Given this list of marker genes MYLK2, ANKRD10, ABL1, ATP1B3, AIPL1, SS18L1, WFDC12, STK4, ANO6, GPALPP1, HOXC6, PHACTR4 (NCBI Gene Id 65979), HS3ST3B1, KLRK1, CRABP2, ERO1A, BTN3A2, EDA, MINK1, CDH18, MTSS2, RIIAD1, AP4B1, IRF6, HMGCR, MYRIP, PDE3B, DHRS2, MAP3K11, MCRIP1, GPRC5B, PCDH7, MYRF, TMEM100, DAGLA, RAB11FIP5, BRF1, here is a description of the gene set: from publication Chen Y, Wang X (PMID 31504780) Human Gene Set: MIR6859_3P species: Homo sapiens Genes predicted to be targets of miRBase v22 microRNA hsa-miR-6859-3p in miRDB v6.0 with MirTarget v4 prediction scores > 80 (high confidence targets).